Given this list of marker genes SLC7A8, PLCXD2, ARF3, ZNF781, LSMEM2, DLG2, MAPK1, ZNF74, SNCA, LYPD6, RBL2, RTN4IP1, CCNT1, FJX1, VPS53, PKIB, MFAP3L, LRRN1, ENDOV, ZNF189, NUFIP1, PPM1A, ZNF229, GPAT3, KIAA1671, HIPK3, SLC30A8, PPM1E (NCBI Gene Id 22843), TSEN2, ZNF107, NUMB, CFAP54, EPOP, ZNF135, RAP2C, MAP1B, COQ10B, ZNF493, BLOC1S6, KHDC1, FKBP5, ZMAT2, SETD7, DNM3, RBPMS (RNA binding protein, mRNA processing factor), ARRB1, ZNF780B, GRIA2, FKBP1A, EPG5, CACYBP, EIF4G2, SLC2A5, SNX18, CD200R1L, UBE4A, CAPZA1, RAB2A, here is a description of the gene set: Human Gene Set: MIR6511A_3P_MIR6511B_3P studied in species Homo sapiens Genes predicted to be targets of miRBase v22 microRNA hsa-miR-6511a-3p, hsa-miR-6511b-3p in miRDB v6.0 with MirTarget v4 prediction scores > 80 (high confidence targets). from publication Chen Y, Wang X (PMID 31504780)